Given this list of marker genes RELA, HMOX1, APP, CASP1, TXNIP, NFKB2, PSTPIP1, hly, SUGT1, P2RX7, NLRP3, TXN, HSP90AB1, PYCARD, NFKB1, PANX1, MEFV, here is a description of the gene set: species: Homo sapiens Reactome Pathway: The NLRP3 inflammasome part of: Inflammasomes The NLRP3 (Cryopyrin) inflammasome is currently the best characterized. It consists of NLRP3, ASC (PYCARD) and procaspase-1; CARD8 (Cardinal) is also suggested to be a component. It is activated by a number of pathogens and bacterial toxins as well as diverse PAMPs, danger-associated molecular patterns (DAMPS) such as hyaluronan and uric acid, and exogenous irritants such as silica and asbestos (see Table S1 Schroder & Tschopp, 2010).<br> Mutations in NLRP3 which lead to constitutive activation are linked to the human diseases Muckle-Wells syndrome, familial cold autoinflammatory syndrome and NOMID, characterized by skin rashes and other symptoms associated with generalized inflammation. The cause of these symptoms is uncontrolled IL-1 beta production. Multiple studies have shown that activation of the NLRP3 inflammasome by particulate activators (e.g. Hornung et al. 2008) requires phagocytosis, but this is not required for the response to ATP, which is mediated by the P2X7 receptor (Kahlenberg & Dubyak, 2004) and appears to involve the pannexin membrane channel (Pellegrin & Suprenenant 2006). Direct binding of activators to NLRP3 has not been demonstrated and the exact process of activation is unclear, though it is speculated to involve changes in conformation that free the NACHT domain for oligomerization (Inohara & Nunez 2001, 2003).